The following is a description of a gene set: Mouse Gene Set: REACTOME_COMPLEX_I_BIOGENESIS species: Mus musculus Complex I biogenesis, and this is the list of marker genes: Tmem126b, Ndufs3, mt-Nd1, Ndufaf3, Dmac2 (distal membrane arm assembly complex 2), Ndufa1, Ndufb1, mt-Nd3, Ndufa9, Ndufb8, Ndufb11, Ndufb4, Ndufaf2, Ndufa5, Ndufs6, Ndufaf4, Ndufa10, Ndufaf7, mt-Nd6, Timmdc1, Ndufaf5, mt-Nd5, Ndufa11, Ndufb7, Ecsit, Ndufv3, Hspa9, Ndufb5, Ndufs4, Lyrm2, Ndufs2, Ndufc2, mt-Nd4, Ndufb9, Ndufa13, Ndufaf1, Tmem186, Hscb, Ndufs1, Ndufv1, Ndufc1 (NCBI Gene Id 66377), Ndufaf8, Ndufb2, Ndufa2, Ndufab1, Ndufa12, Pyurf, Ndufb6, Ndufb3, Ndufa8, Nubpl, Ndufa3, Dmac1, Ndufs5, Acad9, Ndufaf6, Ndufb10, Ndufa7, Ndufa6, Ndufs8, Ndufv2, Ndufs7, mt-Nd2